Given this list of marker genes CACNA2D1 (NCBI Gene Id 781), CASK, PHIP, SNAP91, PLCB1, KBTBD2, UBR3, C8orf34, FASLG, SEC63, LRIG1, DSC3, RBMS1, RNF139, JARID2, MAK, ZDHHC21, PCLO, SALL1, ATP5MC3, RASGEF1A, CXXC4, CYP2F1, KCTD12, IRF6, EPHA3, GPR180, KCNK1, KLHDC1, PPP2R2C, PLPPR4, RAP1A, SLC38A2, MAP4K3, BRD10, ZNF217 (NCBI Gene Id 7764), ETV1, ABCA10, FRMD4B, PDZRN3, FPGT, SIN3A, TIPARP, SIRT1, DGKD, RNF130, NR4A1, SPINK6, RIMS2 (regulating synaptic membrane exocytosis 2), RBBP6, AMOTL1, ICOS, CNTRL, HSPA12A, EEIG2, SPRY1, KHDRBS1, SORBS2, CYYR1, ZBTB10, MIER3, KMT2E, SLC20A2, SKIL, PCNA, FNIP1, ANKRD42, MSI2 (NCBI Gene Id 124540), PHYKPL, FAM221A, ELAVL2, LIN54 (lin-54 DREAM MuvB core complex component), SEC24B, PIK3R1, SETBP1, RHOT1, ATAD2, EPYC, KCNA2, UBE2T, GRHL1, PRR12, PPP2R5C, CCDC28A-AS1, GSR, PHF20L1 (NCBI Gene Id 84165), TXLNG, SCN1A, MGAT4A, ALDOC, GBP4, ARSB, TNFRSF1A, UBR5, PCNP, SSH2, DOCK9, NUP37, PTPN5, NF1, DCUN1D1, CCNT2, AHSA1, ANO4, RNF11, BTG1, NUP98, SLC25A12, NSMCE4A, VEGFA, YPEL2, NXPH1, SUMO2 (NCBI Gene Id 6613), FAM43A, MAP3K2, KALRN, CLDN18, NCAPD3, MRTFB, SLC24A2, CCSER2, SDCBP, KCNJ6, MIER1, RAB37, HSDL2, BPTF, TAB3, UBE2K, ZNF563, ASF1A, NKTR, SPEF2, TOR1B, KLF9, PCDH17, EMSY, BDNF, CXADR, SIX4, RNF220, here is a description of the gene set: studied in species Homo sapiens from publication Chen Y, Wang X (PMID 31504780) Human Gene Set: MIR12129 Genes predicted to be targets of miRBase v22 microRNA hsa-miR-12129 in miRDB v6.0 with MirTarget v4 prediction scores > 80 (high confidence targets).